Given this list of marker genes FOXE1 (NCBI Gene Id 7081), ATM, BCL2L11, HES1, BCL3, NFKB2, STAT5B, RET, ZBTB1, LTB, ADAM17, MAD1L1, BRAF, LMO4, SIX4, ABL1, CDKN2B, ZMPSTE24, ONECUT1, FGF10, PTPRC (NCBI Gene Id 5788), RAG1, PPP2R3C, RIPK3, SLC46A2, TNFRSF11A, ASXL1, MAP2K2, PBX1, MAPK1, POLB, BARX1 (BARX homeobox 1), KMT2A, GATA3, TRAF3IP2, MYB, FAM210B, AIRE, ARTN (NCBI Gene Id 9048), RCBTB2, RAF1, CACNB4, RC3H1, CD2AP, PDPN, CRKL, RC3H2, CITED2, COA5, SOD1, TP53, IL15, HOXB4, BCL2, SHH, CXCR5, ADA, PITX2, LTA, FADD, BCL11B, MAFB, SPNS2, PKN1, RORC, LRRC17, PSEN1, LIPA, TBX1, MAP2K1, EPB42 (NCBI Gene Id 2038), CTC1, TGFBR1, PRDX2, SIX1, IL7R, SBDS, PCID2, JARID2, HOXA3, FOXL1, HAND2, ID2, CDH17, CTNNB1, NKX3-2, STAT5A, NKX2-3, RBM15, FOXI3, FOXN1, FLVCR1 (NCBI Gene Id 559), TYR, TOX, TCF21, EPHB3, NFKBIZ, LRP5, MAPK3, LTBR, SLC40A1, NKX2-5, SRF, CD248, TGFB1, CCNB2, here is a description of the gene set: Human Gene Set: GOBP_HEMATOPOIETIC_OR_LYMPHOID_ORGAN_DEVELOPMENT The process whose specific outcome is the progression of any organ involved in hematopoiesis (also known as hemopoiesis) or lymphoid cell activation over time, from its formation to the mature structure. Such development includes differentiation of resident cell types (stromal cells) and of migratory cell types dependent on the unique microenvironment afforded by the organ for their proper differentiation. species: Homo sapiens